The following is a description of a gene set: Mouse Gene Set: REACTOME_TRYPTOPHAN_CATABOLISM studied in species Mus musculus Tryptophan catabolism, and this is the list of marker genes: Haao, Kynu, Tdo2, Slc36a4, Ido2, Slc7a5, Aadat, Kmo (kynurenine 3-monooxygenase), Ido1 (indoleamine 2,3-dioxygenase 1), Kyat1, Slc3a2